The following is a description of a gene set: Mouse Gene Set: GOCC_APICAL_PLASMA_MEMBRANE The region of the plasma membrane located at the apical end of the cell. species: Mus musculus, and this is the list of marker genes: Psg21, Slc7a8, Slc6a8 (NCBI Gene Id 12911), Slc6a18, Abcc1, Aqp8, Slc5a3, Ctsb (NCBI Gene Id 210034), Atp6v1g1, Atp1b2, Gnat3, Slc47a1, Notch1, Prkcz, Ecrg4, Slc3a1, Prkab2, Ocln, Psg17, Gjb6, Crb1, Podxl, Ace2, Kcnc2, Abca7, Sytl4, Fas, Cd36, Dpep1, Slc2a1, Atp2b2, Atp6v0a4, Gnas, Kcna5, Pdpn, Slc34a3, Otog (NCBI Gene Id 269917), Atp6v1b2, Fzd6, Frmd6, Prom1, Slc22a1, Rhcg, Abcb1a, Atp7a, Abcb11, Slc30a5, Dram2, Slc2a9, Vangl2, Cacnb3, Mpdz, Aqp5, Spef1, Trpv5, Upk1a, Slc4a5 (NCBI Gene Id 232156), Pard6b, Psg29, Osmr, Abcc5, Mip, Anxa1, Stc1, Cfap126, Hpn, Kcnn4, Ajap1, Crb2, Rapgef2, Erbb3, Slc24a4, Ajm1, Emp2, Mtcl1, Shroom4, Slc23a1, Slc26a7, Slc22a7, Slc2a13, Slc34a2, Kcnk1, Cldn25, Myo7a, Prkg2, Trf (transferrin), Slc38a1, Slc20a2, Slc3a2, Stk39, Dsg1b, Slc14a2, Ush2a, Amotl2, Slc9a3, Slc12a3, Slc6a14, Rab14, Car4, Gp2, Slc34a1, Slc43a1, Adam17, Enpep, Akr1a1, Nrg1, Ager, Mtdh, Adcy8, Kcnk2, Slc5a2, Muc1, Slc2a2, Cd44, Atp1b1, Cblif, Slc7a5, Cyp4f15, Numb, Cripto, Vamp3, Shroom3, Cd34, Sipa1l3, Slc7a12, Cd81, Cav1, Hyal2, Slc9a1, Gabrp, Adrb2, Patj, Ceacam11, Chrna7, Abcg5, Cyp4a30b, Ap2a1, Il18, Trpa1 (NCBI Gene Id 277328), Cspg4, Cldn1, Tek, Slc9a4, Slc47a2, Cybrd1 (NCBI Gene Id 73649), Trpv4, Egfr, Nod1, Ctsl, Slc19a1, Mlc1, Pard3b, Stxbp3, Dstyk, Slc31a1, Upk2, Aspm, Ceacam3, Lrrc15, Nherf2, Tjp3, Dsg1c, Anxa13 (annexin A13), Arhgef18, Shroom1, Slc36a1, Kcnj10, Stx4a, C1qtnf5, Muc20, Tcirg1, Slc17a2, Car12, Rab17, Kcne2, Itpk1, Fzd3, Trpm6, Cldnd1, Slc22a19, Dll1, Kcne1 (potassium voltage-gated channel, Isk-related subfamily, member 1), Muc4, Ahcyl1, Slc28a1, Scnn1a, Shroom2, Scrib, Rab18, Ceacam23, Abcc2, Slc17a1, Rapgef4, Slc16a2, Ptprq, Muc13, Oxtr, Plet1, Pappa2, Mfrp, Slc5a11, Mfsd4b1, Pakap, Ripor2, Slc46a1, Havcr1, Muc17, Cyp4a12a, Cftr, Cyp4a12b, Myrip, Pth1r, Atp6v0d2, Slc4a7, Cyp4a29, Ceacam5, Cacna1d, Psg25, Slc7a9, Aqp2, Slc10a2, Slc4a10, Lct, Vcam1, Pde4d, Kcnma1, Erbb2, Kl, Slc22a3, Marveld2, Dpp4, Slc12a1, Dsg1a, Abcc4, Plpp1, Cdhr5, Grk2, Slc13a2, Slc22a4, Atp6v1a, Slc16a3, Clca4a, Abcg2, Lhfpl5, Cyp4a14, Kiss1, Itgb3, Slc22a5, Mal, Psg27, Ddr2, Rapgef6, Epcam, Ceacam13, Ezr, Jag1, Pdzk1ip1, Plb1, Atp12a, Pdgfrb, Slc4a11, Slc26a2, Dlg1, Cyp4a31, Slc12a6, Pfkm, Fat1, Psg19, Atp6v1e1, Cldn24, Car14 (NCBI Gene Id 99909), Cyp4a10, Hvcn1, Akap7, Mreg, Kcnq1, Tlr9, Il6ra, Ocel1, Fn1, Cldn4 (NCBI Gene Id 12740), P2rx2, Il10ra, Igfbp2, Thy1, Bst2, Ceacam2, Tmem114, Cib1, Tmem235, Asic5, Pdzk1, Slc39a3, Kncn, Slc26a3, Pals1, Ctsk, Aqp1, Clcn3, Ptpro, Slc16a8, Dsg2, Naaladl1, Prkaa2, Pard6a, Slc29a4, Nherf1, P2ry6 (pyrimidinergic receptor P2Y, G-protein coupled, 6), Upk3a, Sapcd2, Rab27b, Slc29a1, Atp6v0d1, Ceacam20, Dcxr, Iqgap1, Cd9, Zmynd10, Cd300lg, Slc44a4, Cdhr2, Slc26a11, Slc6a9, P2ry4 (pyrimidinergic receptor P2Y, G-protein coupled, 4), Gnat1, Atp4b, F2rl2, Hsp90ab1, Amotl1, Slc2a5, Msn, Gpihbp1, Slc6a19, Slc39a10, Atp1b3, Casr, Pkhd1, Slc6a20b, Slc22a21, Prkaa1, Stk26, Ctnnb1, Slc9a2, P2ry1, Slc6a6, Pld1, Kcna1 (NCBI Gene Id 17205), P2ry2, Septin7, Slc5a1, Mpp3, Ceacam1, Psg20, Cd55b, Lmo7, Mal2 (NCBI Gene Id 223579), Slc2a7, Slc22a13, Prom2, Pten, Slc26a6, Slc26a9, Gm2a, Sptbn2, Tmem30a, Ptk2, Slc15a1, Slc22a12, Slc22a8, Upk1b, Slc9a8, Cyp4f14, Abcg8, Slc23a2, Slc39a6, Adgrg2, Myh9, Scnn1b, Hsp90aa1, Slc17a5, Abcb4, Amn (amnionless), Slc12a2, Slc9b2, Abcb5, Bmpr2, Anxa6, Psg26 (NCBI Gene Id 574429), Myo1a, Pard6g, Slc5a7, Prkci, Anxa4, Psg28, Cnksr3, Slc17a3, Folr1, Umod (NCBI Gene Id 233798), Atp6v1b1, Rab27a, Clic5, Slc5a8, Slc11a2, Atp6ap2, Enpp3, Cd55, Cyp4f18, Sorbs2, Abcc6, Lrp2, Npc1l1, Tnik, Fxyd1, Gpr143, Atp1a1, Slc26a4, C2cd2l, Ptprh, Slc22a18, Slc5a10, Cdh2, Kcne4, Slc13a1, Pllp, Eps15, Psg23, Slc17a4, Slc5a6, Crb3, Slc7a1, Slc15a2, Slc4a2, Kcnb1, Slco2b1, Atp8b1, Cntfr (ciliary neurotrophic factor receptor), S100g, Slc38a3, Wdpcp, Cubn, Scnn1g, Slc29a2 (solute carrier family 29 (nucleoside transporters), member 2), Slc22a2, Hip1r, Lzts1, Pdia3, Dab2, Birc5, Igsf5, Slc5a12, Slc1a1, Stxbp2, Shank2, BC034090, Tjp1, Slc16a1, Stx3, Rdx, Slc6a20a, Pip (NCBI Gene Id 18716), Slco3a1, Zpld2, Abcb1b, Mgam, Slc7a13, Nox4, Hax1, Cyp4a32, Tgfbr1, Acy3, Itpr3, Slc4a8, Adcy10, Gja1, Nherf4, Slc39a4, Atp4a, Clcnka, Plec, Hspa1a, Hspa1b, Atp2b1, Ano1, Pard3, Tmem174, Slc39a14, Otoa, Slc39a8, Cyba